The following is a description of a gene set: Human Gene Set: GOBP_TETRAHYDROBIOPTERIN_METABOLIC_PROCESS The chemical reactions and pathways involving tetrahydrobiopterin, the reduced form of biopterin (2-amino-4-hydroxy-6-(1,2-dihydroxypropyl)-pteridine). It functions as a hydroxylation coenzyme, e.g. in the conversion of phenylalanine to tyrosine. species: Homo sapiens, and this is the list of marker genes: PTS, PCBD1, DHFR, SPR, QDPR, NOS3, GCH1, PRKG2, PCBD2, DHFRP1